Given this list of marker genes GLRA2, SLC26A9, CFTR, SLC4A1, ANO3, ANO5, ANO6, STX7, SLC12A6, SLC22A1, SLC4A10, SLC26A8, TTYH1, SLC17A6, SLC26A1, PACC1, CLCN2, CLCN3, GABRG2, CLDN4, TMC4, CLCA1, SLC12A1, CLCA2, SLC1A1, ANO7, GABRA1, SLC6A8 (NCBI Gene Id 6535), GABRQ, TTYH3, SLC1A7, SLC12A4, SGK1, SLC26A10P, CLIC2, SLC18A1 (NCBI Gene Id 6570), GABRB3, SLC26A3, CLCN5, SLC17A8, SLC12A5, CLIC4, BEST3, NHERF1, BEST4, CLIC6, SLC26A7, SLC26A6, SGK3, OCA2, GABRR1, GABRA6 (NCBI Gene Id 2559), GLRB, SLC6A1, SLC6A6, ANO2, FXYD1, CLIC3, VAMP8, APOL1, CLCC1, NMUR2, GABRR3, STX8, GABRP, SLC18A2 (solute carrier family 18 member A2), BSND, GABRG1, CLCNKB, VTI1B, SLC6A12, SLC12A3, BEST2, SLC6A2, CLCN1, SLC4A8, GABRE, FXYD3, CLIC1, SLC6A18, GABRA2, SLC4A3, SLC6A13, SLC26A5, SLC25A14, SLC6A3, CLDN17, SLC17A7, GABRR2, SLC25A27 (solute carrier family 25 member 27), SLC1A4, GABRA3, CLCN4, GABRD, SLC12A9, SLC6A11, CLCNKA, SLC26A2, GABRA4, TTYH2, ANO10, ANO1, GABRA5, AQP6, CLCN6, SLC12A8, UCP2, GABRB2, CLCA4, ANO4, C8orf44-SGK3, SLC26A4, GLRA3, CHRNA7 (cholinergic receptor nicotinic alpha 7 subunit), CLCN7, GABRG3, SLC12A7, SLC4A2, SLC26A11, GLRA1, SLC12A2, ANO9, SLC6A4 (solute carrier family 6 member 4), BEST1, ANO8, GABRB1, STX1A, MFSD8, SLC4A9, CLIC5, here is a description of the gene set: Enables the transfer of chloride ions from one side of a membrane to the other. species: Homo sapiens Human Gene Set: GOMF_CHLORIDE_TRANSMEMBRANE_TRANSPORTER_ACTIVITY